The following is a description of a gene set: Human Gene Set: WP_MITOCHONDRIAL_COMPLEX_II_ASSEMBLY Mitochondrial complex II assembly studied in species Homo sapiens, and this is the list of marker genes: SDHA, SDHB, SDHAF1, SDHC, SDHAF4, SDHD, SDHAF3, SDHAF2